The following is a description of a gene set: Mouse Gene Set: GOBP_DOUBLE_STRAND_BREAK_REPAIR studied in species Mus musculus The repair of double-strand breaks in DNA via homologous and nonhomologous mechanisms to reform a continuous DNA helix., and this is the list of marker genes: Parp2, Rhno1, Peli1, Pot1b, Rmi2, Vcp, Kmt5b, Cdc7, Ddx11, Arid1a, Meiob, Fignl1, Setx, Setmar, Zfp365, Hdgfl2, Khdc3, Fan1, Cdc45, Atm, Mus81, Hsf2bp, Hsf1, Rad51b, Aunip, Poln, Dclre1b, Majin, Xrcc6, Fancd2, Ube2v2 (ubiquitin-conjugating enzyme E2 variant 2), Ubqln4, Radx, Vps72, Ppp4r3c1, Uimc1, Brip1, Rpa3, Mrgbp, Mcm7, Inip (NCBI Gene Id 67176), Ddx1, Zfyve26, Mcm9, Trip13, Mpnd, 4930447C04Rik (NCBI Gene Id 77831), Rad54l, Nsmce1, Brcc3dc, Smarcc2, C1qbp, Ercc6, Poll, Mcm6, Wrap53, Slf1, Ercc4, Rev3l, Ercc5, Smarcc1, Palb2, Ogg1, Timeless, Was, Nbn, Rad52, Tdp2, Polm, Rmi1, Csnk2a1, Fbh1, Brca2, Smc5, Rad54b, Polq, Msh2, Cyren, Babam1, Ruvbl1, Morc2b, Actb, Top2b, Dpf1, Eya1, Parp9, Sem1, Smarcad1, Ppp4r3c2 (protein phosphatase 4 regulatory subunit 3C2), Abl1, Klhl15, Lig4, Plk1, Exd2, Pias4 (NCBI Gene Id 59004), Blm, Dmap1, Otub1 (NCBI Gene Id 107260), Chek2 (checkpoint kinase 2), Prdm9, Mad2l2, Trrap (NCBI Gene Id 640386), Shld2, Dna2, Kdm2a, Swsap1, Rif1, Topbp1, Eme2, Mcm4, Aplf, Nucks1, Lig1, Slf2, Pbrm1, Rnf138rt1 (NCBI Gene Id 74264), Rpa2, Smc6, Mcm2, Gins4, Nsd2, Helq, Dclre1c, Wdr48, Prpf19, Ube2n, Polb (polymerase (DNA directed), beta), Yy1, Setd2, Smchd1, Spo11 (SPO11 initiator of meiotic double stranded breaks), Pot1a, Smarcb1, Esco2, Actr5, Arid2, Actl6a, Smarcd3, Abraxas1, Zcwpw1, Smarcd2, Ppp4c, Rad51d, Dmc1, Hmga2, Actr8, Shld3, Shld1, Mcm5, Wrn, Hmgb1, Actl6b, Sfpq, Ing3, Mcmdc2, Ggn, Mre11a, Nabp2, Ercc1, Rad51c, Rad21l, Terb2, Mgmt, Spire2, Csnk2a2, Phf10, Kmt5c, Skp2, Ruvbl2, Prkdc, Apbb1, Rbbp8, Dntt, Rec8, Hmces, Atrip, Xrcc5, Xrcc2, Ppp4r3a, Dpf3, Spidr, Fmn2, Brme1, Rnf168, Terb1, Smarce1, Morf4l1, Xrcc3, Ino80, Ercc8, Trp53, Actr2, Kash5, Brd7, Spire1, Smarca4, Nipbl, Ooep, Meioc, Mcm3, Terf2ip, Fancm, Zbtb7a, Tonsl, Rad21, Senp3, Top3a, Epc1, Pml, Dclre1a, Recql, Rad51, Nabp1, Chd4, Mbtd1, Kdm4d, Yeats4, Eme1, Slx4, Pola1, Ap5z1 (adaptor-related protein complex 5, zeta 1 subunit), Pnkp, Dpf2, Htatsf1, Morf4l2 (NCBI Gene Id 71961), Helb, Hpf1, Hus1b, Sirt6, Fh1 (NCBI Gene Id 14194), Smarcd1, Parp3, Ints3, Trp53bp1, Kdm1a, Parp1, H2ax, Zmynd8, Atr (NCBI Gene Id 382093), Dtx3l, Zswim7, Swi5, Cdca5, Ppp4r3b, Rnf138, Eya3, Sfr1, Brca1, Fus, Uvrag, Kmt5a, Xrcc4, Crebbp, Foxm1, Ankle1, Hus1, Ppp4r2, Aste1, Rnf126, Rpa1, Rnf8, Chek1, Parpbp, Samhd1, Usp51, Mta1, Paxx, Brd8, Rad51ap1, Slx1b, Nhej1, Psmd14, Ep400, Babam2, Iffo1, Mms22l, Bcl7c, Xrcc1, Nudt16l1, Bend2, Recql5, Pogz, Marf1, Kat5, Nsmce2, Ap5s1, Rfwd3, Bcl7b, Bcl7a, Lig3, Smarca2, Fancb, Rtel1, Tdp1, Gen1 (NCBI Gene Id 209334), Ager, Mrnip, Rnf169, Recql4, Rad50, Mlh1, Smarcal1, Dek, Mcm8, Prmt1, Cgas, Twist1, Sirt1, Tnks1bp1, Gins2, Epc2, Tex15, Brcc3, Meaf6